Given this list of marker genes MPP3, PLK2, TM2D3, VKORC1, KLF4, CD22, ACYP1, XPC, ZYG11B, NR1D2, GATM, CCND2, PISD, JCHAIN, CCR6, HPS1 (HPS1 biogenesis of lysosomal organelles complex 3 subunit 1), PTPRS, NECAP1, CXXC5, LONP1, ADGRD1, FEM1B, CASK, IGHG1, SCD, PTK6, DDX24, MLLT10, FCGR2B, PLEKHA1, RABEPK, RPL30, HLA-DOB, FPR1, IL6R, RNF141, PNRC1, CD40, ERAL1, VLDLR, AARD, INPP5A, TFCP2, GPR3, RECQL5, RGL2 (ral guanine nucleotide dissociation stimulator like 2), POLG, HSD17B8, CXCR5, IRF5, POU6F1, TOMM34, LAPTM5, RPS25, REM1, RPS6KC1, ALG2, FOXP1, TCF7, GNG12, TCF4, ASGR2, SCG5, MROH1, CFP (NCBI Gene Id 5200), NSG2, RHD, NIT2 (NCBI Gene Id 56954), SBF2, AKAP9, CRAMP1, IL7R, RRM2B, MUTYH, AHI1, AXIN1, RALY, FURIN, CAMK2B, ABCC5 (ATP binding cassette subfamily C member 5), RHOB, ABCG1, DNAJB2, CHI3L1, PLXNB2, IGF1R, HSD17B11, ERCC2, SLC11A2, SLC7A7, CXCL13, ZNF282, SPOUT1, POU2AF1, FCRLA, GGA2, IPO4, SLPI, FABP2, RPL5, PCCB, HBB (NCBI Gene Id 3043), HHEX, RALGPS2, CD4, RFLNB, ZNF821, MAT2A, MAU2, LY86, CADM1, IL13RA2, CREG1, IGKC, RPS19, CTSK, TPST1, OVGP1, NKIRAS1, PER1, ZBTB20, HTRA2, PIM1, PRNP, CYP2J2, PABPN1, FCER2, PDE4B, CCR1, EVL, SMAD7, TAPBP, HOXC5, VAMP2, BCL2L2, GALNT10, TJP1, TSC22D1, SLFN12, P2RX4, PTGFR, C19orf48P, H1-2, BLK, RGS10, WASF2, DALRD3, CDK11B, HOXC4, ZSCAN26, SUN2, CNGA1, CREBBP, ZPBP, SVIL, SLC26A2, EMD, CNOT4, PKD1, DUSP6, IGLC7, RPL14, IL1B (interleukin 1 beta), LSM14B (LSM family member 14B), POMGNT1, ARID3B, PRMT3, DGCR6, RIN2, SH2B3, GLUL, KMT2A, POU2F1 (NCBI Gene Id 7823), SELL, IDUA, ADCY6, WDR74, E2F5, RABGAP1L, PARP8, ZNF398, BCL6, DVL1, MYL4, D2HGDH, NEDD4L, KCNJ8, BAD, IGFBP4, AQP9, DTD2, TDRP, KIAA0930, ARRB1 (NCBI Gene Id 408), SLC3A2, JUND (JunD proto-oncogene, AP-1 transcription factor subunit), MPHOSPH10, RERE, PCSK5 (NCBI Gene Id 96284), GADD45A, here is a description of the gene set: Genes down-regulated in effector CD8 T cells at the peak expansion phase (day 8 after LCMV-Armstrong infection) compared to effector CD8 T cells at contraction phase (day 15 after LCMV-Armstrong infection). from publication Kaech SM, Hemby S, Kersh E, Ahmed R (PMID 12526810) Human Gene Set: KAECH_DAY8_EFF_VS_DAY15_EFF_CD8_TCELL_DN How and when memory T cells form during an immune response are long-standing questions. To better understand memory CD8 T cell development, a time course of gene expression and functional changes in antigen-specific T cells during viral infection was evaluated. The expression of many genes continued to change after viral clearance in accordance with changes in CD8 T cell functional properties. Even though memory cell precursors were present at the peak of the immune response, these cells did not display hallmark functional traits of memory T cells. However, these cells gradually acquired the memory cell qualities of self-renewal and rapid recall to antigen suggesting the model that antigen-specific CD8 T cells progressively differentiate into memory cells following viral infection. studied in species Homo sapiens